The following is a description of a gene set: Genes predicted to be targets of miRBase v22 microRNA hsa-miR-6873-5p in miRDB v6.0 with MirTarget v4 prediction scores > 80 (high confidence targets). from publication Chen Y, Wang X (PMID 31504780) studied in species Homo sapiens Human Gene Set: MIR6873_5P, and this is the list of marker genes: ZXDB, RIMS4, UCP2, SI, C6orf120, TOB2, PRSS23, DAP, MYOCD, WDFY2, LRRC55, ZNF827, SLF2, SLC15A4, ZMAT2, TMEM127, AGAP1, MYO9A, ANKRD36B, GASK1B, CNDP2, SLC38A1, ZNF706, DGKG, RPTN, GSTT2B, PLOD2, NR5A1 (nuclear receptor subfamily 5 group A member 1), PRSS37, STUM, ZNF703, WNT1, TLL2, GRAMD2A, CERS2, C10orf95, SETD3, RELCH, SLC13A3, GNGT2, GLIS2, KLHL12, CNTLN, USP51, DCLK2, ADGRG6 (adhesion G protein-coupled receptor G6), EXOG, DCAF7, ATAT1, SET, DACT2, DKK3, BCAM, TMEM164, DNAJC14, ADCY6, KCNJ2, GABRA4, SLC22A23, GJB1, CAMK4, IL1RAP, ILRUN, CACNA1E, NOVA2, RBM14, ZSCAN29, TWIST2, CFAP418, HECTD2 (HECT domain E3 ubiquitin protein ligase 2), TSPAN7, CEP350, KRT4, VANGL2 (VANGL planar cell polarity protein 2), VAX1, ANKRD36C, KLHL34, LILRA1, CD200R1, LAMC1 (NCBI Gene Id 3915), DNAI3, NFAT5, ZMIZ1, SMG1 (SMG1 nonsense mediated mRNA decay associated PI3K related kinase), PTK2B, KLF5, SLC7A8, ARG1, POLR1D, FASTKD2, PRICKLE3, WIZ, DNMT3B, IDS, CELF3, SPAG9, RASGRP4, KIF21B, SRSF2, ADIPOR2, SAMD4A, NUDT3, NPTX1, ST8SIA3, FKBP4, EXOC7, KMT2A, CDSN, STRN4, FGF1, BIRC5, TRAK1